Given this list of marker genes MYO9A, ADAT3 (NCBI Gene Id 113179), YY1, FAM20C, ABCC8, COL13A1, SYNE1, CEP55, ZNHIT3, EXOSC9, KIF14, LMOD3, CHST14, SCN4A, AGTPBP1, TRPV4, CHRNA1, UBA1, POMT1, SLC5A7, SOX10, AUTS2, TRIP13, MED13L, GLE1, GNPTAB, MYPN, TGFB3, VRK1, EXOSC3, MYBPC1, SLC25A1, NEB, PLXND1, RAPSN, GCK, CACNA1E, OTUD5, VAMP1, GFPT1, NALCN, SLC25A46, ADGRG1 (NCBI Gene Id 9624), DSE (NCBI Gene Id 29940), PIGS, ERCC2, PIP5K1C, MYOD1, TBX4, GBE1, SMPD4, PLEC, CFL2, LMNA, ACTA1, VPS33B (NCBI Gene Id 55513), SLC35A3, ZBTB42, KCNJ11, ACADM, ADCY6, CHMP1A, CCDC47, VIPAS39, AGRN, PLOD2 (procollagen-lysine,2-oxoglutarate 5-dioxygenase 2), KAT6B, FKBP10, ALG3, CAPN3, LAMA5, SLC18A3, CDK5, TPM3, PDX1, MYH3 (NCBI Gene Id 4621), KLHL40, TPM2, DHCR24, INS, GLDN, ERGIC1, GLI3, GBA1, ASXL1, PPP3CA (protein phosphatase 3 catalytic subunit alpha), COL6A1, ERCC6, ITGB4, EXOSC8, TUBA1A, FKRP, REEP1, COL12A1, STAC3, ERCC1, REV3L, COQ4, PI4KA (NCBI Gene Id 5297), TOR1A, SCYL2, KIDINS220, BLTP1, ZNF335, ASCC1, NRCAM, HSPG2, KIF5C, SLC6A9, NUP88, ALG14, DOK7, MTRFR, EXOC7, IBA57, RIPK4, ERBB3, ERCC5, ATAD1 (ATPase family AAA domain containing 1), PRG4, MYH2, MORC2, CHRNE, FKTN, LZTR1, KCNK9, PIEZO2, LARGE1, TBCD, GFM2, MAGEL2, CHRNG, LGI4, CNTNAP1, CHAT, ADGRG6, KBTBD13, KIF26A, KLHL41, ZMPSTE24, MYH8, POMT2, PAX7, CLCN3, SNAP25, GNB2, SHPK, MUSK, ZC4H2, TNNI2, FIG4, RFT1, ADAMTS15, DPM2, SYT2, FBN2, TRIP4, TSEN54, STAT3, BICD2, SRPX2, NEK9, RYR3, DNM2, KIF21A, here is a description of the gene set: Human Gene Set: HP_CONGENITAL_CONTRACTURE studied in species Homo sapiens Congenital contracture One or more flexion contractures (a bent joint that cannot be straightened actively or passively) that are present at birth.